The following is a description of a gene set: Human Gene Set: GOBP_REGULATION_OF_EOSINOPHIL_MIGRATION Any process that modulates the frequency, rate or extent of eosinophil migration. species: Homo sapiens, and this is the list of marker genes: ADAM8, CCL24, CD300A, DAPK2, PTGER4